Given this list of marker genes TMEM270, IQSEC2, CLIP2, FKBP6, EDNRA, BAZ1B, CREBBP (NCBI Gene Id 1387), METTL27, SCN1A, EP300, DEAF1, FLII, GTF2IRD1, NCF1, STX1A, PPM1D (protein phosphatase, Mg2+/Mn2+ dependent 1D), MLXIPL, ELN, DNAJC30, RFC2, GM2A, GTF2IRD2, TBL2, LIMK1, TNF, SLC1A3, EIF4H, NSUN2, GTF2I, BUD23, TRIO, RAI1, HEXB, NAA60, VPS37D, LIG4, ESR1, UBAP2L, here is a description of the gene set: studied in species Homo sapiens Human Gene Set: HP_AUDITORY_HYPERSENSITIVITY Auditory hypersensitivity Hyperresponsive to sound that is abnormal in intensity and/or frequency.